Given this list of marker genes Pkm, Lmnb1, Ctsz, Cd52 (CD52 antigen), Csf1r, Plek, Rnh1, Wfdc17, Arpc1b, Ccr2, Msrb1, Ddit3, Fcgr2b, Eno1, Ms4a6b, Ly86, Srgn, Ms4a4c, Mafb, Ptprc, Atox1, Lyz2, H3f3a, Gda, Atp6v1c1, H2-DMa, Plac8, Alox5ap, Ctsb, Got1, Ctsa, Fem1c, Coro1a, Ifitm3, Sat1, Ms4a6c, Picalm, S100a4, Mcl1, Mpeg1, B2m, Ccl9, Cst3, Atp6ap2, Slc3a2, Grn, Capza2 (capping actin protein of muscle Z-line subunit alpha 2), Slfn2, Cybb, Pld4, Lcp1, Lgmn, C1qb, Fcgr3, C1qc, Pfn1, C5ar1, Ifi207, Csf2ra (colony stimulating factor 2 receptor, alpha, low-affinity (granulocyte-macrophage)), H2-D1, Cxcl2, Dusp5, Cd74, Esd (NCBI Gene Id 51790), Cd86, Ftl1, Sdcbp, Unc93b1, Arhgdib, Rilpl2, Ifi27l2a, Litaf, Aif1, H2-DMb1, Fth1, Ifi204, Kctd12, Cstb, Ctss, Cotl1, Rab8b, Rap1b, Laptm5, H2-Eb1, Cytip, Spp1, Csf2rb, Iqgap1, Rab20, Actr3, Il1b, H2-Aa, Lat2, Vps37b, Eif4a1, Cd44, Lst1, Psap, Osm (NCBI Gene Id 18413), Ly6e, Ccl4 (C-C motif chemokine ligand 4), Cd68, H2-Ab1, Lilrb4a, Irf5, H2az1, Samhd1, Cd83, Por, Rgs1, Btg1, Plaur, H3f3b, Rac2, Npc2, Sdc3, Emp3, Taldo1 (transaldolase 1), Ubl3, Rab7b, Ptpn1, Irf7, Cd53, Ccl6, Calm1, Fxyd5, Ly6c2, Fcer1g, Emilin2, Arpc2, Fth1-ps, Tpd52, Cdkn1a, Ctsc, Efhd2, Psmb8, Ifrd1, Ucp2, Mdm2, Tgfbi, Tyrobp, Apoe, Tmsb4x, Ftl1-ps1, Thbs1, Crip1, Tgif1, Fcgr1 (NCBI Gene Id 99852), Lgals3, Atp2b1, Clec7a, Cd14, Cycs, Cfp, Arpc3, Cyrib, Card19, Ninj1, Itgb2, Spi1, Plin2, Cyba, Clec4e, Ms4a6d, Hmox1, Prdx5, Ccr1, Plbd1, Pim1, Lilrb4b, Sh3bgrl3, here is a description of the gene set: from publication Zhang L, Long W, Xu W, Chen X, Zhao X, Wu B (PMID 35669188) Table S2: Representative genes of each cell cluster species: Mus musculus Mouse Gene Set: ZHANG_UTERUS_C12_MONOCYTE